Given this list of marker genes Prkdc, Mettl3, Kat5 (NCBI Gene Id 81601), Cdk6, Setd1a, Pus7, Ythdf2, N4bp2l2, Eif2ak2, Nfe2l2, Tcf15, Hspa9, Zfp36, Foxc1, Tmsb4x (NCBI Gene Id 19241), Ap2a2, here is a description of the gene set: Mouse Gene Set: GOBP_REGULATION_OF_HEMATOPOIETIC_STEM_CELL_DIFFERENTIATION Any process that modulates the frequency, rate or extent of hematopoietic stem cell differentiation. species: Mus musculus